The following is a description of a gene set: The p53 gene is mutated in many human tumors. Cells of such tumors often contain abundant mutant p53 (mutp53) protein, which may contribute actively to tumor progression via a gain-of-function mechanism. We applied ChIP-on-chip analysis and identified the vitamin D receptor (VDR) response element as overrepresented in promoter sequences bound by mutp53. We report that mutp53 can interact functionally and physically with VDR. Mutp53 is recruited to VDR-regulated genes and modulates their expression, augmenting the transactivation of some genes and relieving the repression of others. Furthermore, mutp53 increases the nuclear accumulation of VDR. Importantly, mutp53 converts vitamin D into an antiapoptotic agent. Thus, p53 status can determine the biological impact of vitamin D on tumor cells. Human Gene Set: STAMBOLSKY_TARGETS_OF_MUTATED_TP53_DN Genes repressed in SKBR3 cells (breast cancer) by mutated TP53. from publication Stambolsky P, Tabach Y, Fontemaggi G, Weisz L, Maor-Aloni R, Siegfried Z, Shiff I, Kogan I, Shay M, Kalo E, Blandino G, Simon I, Oren M, Rotter V (PMID 20227041) studied in species Homo sapiens, and this is the list of marker genes: CCL18, OAS3, IFIT1, HERC6, RIGI, ATOSA, CAPN8, SP110, TLDC2, CIRBP, SOCS2, IFITM1, UNG, RAB4B, OAS1, TAGLN, SAMD9, IRF9, SP100, DTX3L, XAF1, CHRM1, RTEL1, IFI6, TBC1D22A, COX4I1, ZP1, TMEM52B, IFI35, DDX60, TSC22D4, RIPOR3, TMEM44, KRT17, RBCK1 (NCBI Gene Id 10616), CD9, STAT1, MX1, ISG15, TRAPPC12, ASAP3, CUEDC1, IRF7, TGFBR1, MICAL3, HLA-B, BST2 (bone marrow stromal cell antigen 2), LBP, SLC40A1, SSH2, DNAI1